The following is a description of a gene set: Mouse Gene Set: GOBP_POSITIVE_REGULATION_OF_HYDROGEN_PEROXIDE_MEDIATED_PROGRAMMED_CELL_DEATH studied in species Mus musculus Any process that activates or increases the frequency, rate or extent of hydrogen peroxide-mediated programmed cell death., and this is the list of marker genes: Pawr, Foxa1, Ep300, Foxp1, Foxo3, Endog